The following is a description of a gene set: Genes predicted to be targets of miRBase v22 microRNA mmu_miR_6368 in miRDB v6.0 with MirTarget v4 prediction scores > 80 (high confidence targets). from publication Chen Y, Wang X (PMID 31504780) Mouse Gene Set: MIR_6368 species: Mus musculus, and this is the list of marker genes: Hspa13, Sptan1, Sv2b, Arid1b, Kcng3, Kpna6, Mtf1, Ppm1f, Acadm, Slc16a5, Scara3, Scp2, Fbxo28, Aamp, Cdh4, Exosc9, Ppp1r1c, Elf2, Zfp94, Gjc3, Pabpc4l, Rab1b, Eda2r, Bmp2, Apol7c, Gpr173, Daam2, Cd38, Ccdc71l, Mtcl2, Apol7a, Snd1, Fhit, Gcnt1 (NCBI Gene Id 71444), Larp1, Tafa1, Fgfr2, Prpf3, Galnt9, Ywhaq, Sptlc3, Pdgfra, Col6a5, Rfk, Agrn, Bbs9, Ralgapa1, Dnajc11, Tyrp1, Grid1, Cyp2c23, Minar2, Rd3 (NCBI Gene Id 74023), Timp3 (NCBI Gene Id 268324), Gstm6 (NCBI Gene Id 14867), Zmat2, Adipor1 (NCBI Gene Id 72674), Nras, Krt33a, Cps1, Commd8, 4931406C07Rik, Atp1b2, Neu3, Serpinf2, Slc25a23, Prokr2, Ctdsp2, Grm5, Smc3, Foxp4, Lyzl6, Mmp20, Zmynd11, Dhrs9, Zfp410, Psg25, Tmem184b (transmembrane protein 184b), Zfx, Gata6, Ablim1, Lyve1, Gtf3c2, Tox, Xaf1, Pafah2, Glg1, Psen1, H2-M10.5, Psme3, Tmem8b (transmembrane protein 8B), Zim1, Neurod4, Bcap29, Dnm3 (dynamin 3), Kcnq5 (potassium voltage-gated channel, subfamily Q, member 5), Cavin2, Foxn2, Gkn2, Krtap31-1 (keratin associated protein 31-1), Lepr, Fam53c, Pitpna, Exoc8, Il20ra, Cntn5, Spata17, Clasp2, Cnr2, Rabl2, Rusc1, Nfia, Srl, Dctn6, Mllt6, Fbxo43, Dtna, Chd3, Srcin1